Given this list of marker genes TALDO1, here is a description of the gene set: Reactome Pathway: TALDO1 deficiency: failed conversion of SH7P, GA3P to Fru(6)P, E4P Mutations in transaldolase 1 (TALDO1), an enzyme of the pentose phosphate pathway that normally mediates the reversible interconversion of sedoheptulose 7-phosphate and D-glyceraldehyde 3-phosphate to form D-fructose 6-phosphate and D-erythrose 4-phosphate, have been associated with congenital liver disease. studied in species Homo sapiens part of: Pentose phosphate pathway disease